The following is a description of a gene set: Binds to and increases the activity of an endopeptidase. Human Gene Set: GOMF_ENDOPEPTIDASE_ACTIVATOR_ACTIVITY species: Homo sapiens, and this is the list of marker genes: HSPD1, AIM2, NCSTN (nicastrin), APH1A (aph-1 homolog A, gamma-secretase subunit), NDUFA13, PSME2, NLRP3, NLRC4, ROCK2, PYCARD, APH1B, PSENEN, TIMM50, VSIR, NLRP1, LGMN, BAD, PSME1, NRDC, APAF1, PSMD14, CARD8, FURIN, ADRM1, MALT1, NLRP12, SFRP2, PSME3, ST20 (suppressor of tumorigenicity 20)